The following is a description of a gene set: from publication Olex AL, Hiltbold EM, Leng X, Fetrow JS (PMID 20682054) Human Gene Set: GSE21033_CTRL_VS_POLYIC_STIM_DC_3H_UP Genes up-regulated in bone marrow-derived dendritic cellstreated by poly(IC): 0h versus 3h. studied in species Homo sapiens BACKGROUND: Dendritic cells (DC) play a central role in primary immune responses and become potent stimulators of the adaptive immune response after undergoing the critical process of maturation. Understanding the dynamics of DC maturation would provide key insights into this important process. Time course microarray experiments can provide unique insights into DC maturation dynamics. Replicate experiments are necessary to address the issues of experimental and biological variability. Statistical methods and averaging are often used to identify significant signals. Here a novel strategy for filtering of replicate time course microarray data, which identifies consistent signals between the replicates, is presented and applied to a DC time course microarray experiment. RESULTS: The temporal dynamics of DC maturation were studied by stimulating DC with poly(I:C) and following gene expression at 5 time points from 1 to 24 hours. The novel filtering strategy uses standard statistical and fold change techniques, along with the consistency of replicate temporal profiles, to identify those differentially expressed genes that were consistent in two biological replicate experiments. To address the issue of cluster reproducibility a consensus clustering method, which identifies clusters of genes whose expression varies consistently between replicates, was also developed and applied. Analysis of the resulting clusters revealed many known and novel characteristics of DC maturation, such as the up-regulation of specific immune response pathways. Intriguingly, more genes were down-regulated than up-regulated. Results identify a more comprehensive program of down-regulation, including many genes involved in protein synthesis, metabolism, and housekeeping needed for maintenance of cellular integrity and metabolism. CONCLUSIONS: The new filtering strategy emphasizes the importance of consistent and reproducible results when analyzing microarray data and utilizes consistency between replicate experiments as a criterion in both feature selection and clustering, without averaging or otherwise combining replicate data. Observation of a significant down-regulation program during DC maturation indicates that DC are preparing for cell death and provides a path to better understand the process. This new filtering strategy can be adapted for use in analyzing other large-scale time course data sets with replicates., and this is the list of marker genes: RAB5IF, BEX4, SMIM8, BRD7, PIM2, TRIM58, ORC1, ARMC6, TSC22D4, COA3, SNUPN, FASTK, TTC33, ZKSCAN4, EI24, JARID2, SLC16A10, PLCB1, MRFAP1L1, ACAD8, COQ8A, PPM1H, POLR3B, SCYL3, HELZ, MRPL17, TTK, CD164, ANXA11, MTMR3, FNBP1, RABEPK, LPCAT4 (lysophosphatidylcholine acyltransferase 4), TNFSF10, UBA7, VIPAS39, TRAPPC2, LRRC47, NDUFC2, AVEN, SLC30A4 (solute carrier family 30 member 4), FN3KRP, PDCL, COASY, FXR1, PIGH, TUT4, RHOG, PSMF1, BCOR, MYH1, HINT1, ELOA-AS1, CRAT, MYO1D, CTNNBIP1, PFAS, MIS18A, RBPJ, TDP2 (NCBI Gene Id 51567), CSE1L, CD244, PTPRA, ZNF768, DCUN1D2, CENPU, RUSF1, KIF11, POU2F1, MEGF9, CDC7, ELMO1, CREG1, CNOT9, ZZZ3, RPRD2, GSTK1, DLGAP5, NPIPA1, PWP1, TSPAN14, CLCN5, TST, MAP3K3, PKD1P6, TMEM177 (transmembrane protein 177), SH2D3A, PIK3R3, MDFIC, REPS1, MDC1, HNRNPUL1, ZNF177, NAP1L4, JUP, FTO, BMAL1, NAT10, ATP5PD, MTERF3, BAG2, RAB4A (RAB4A, member RAS oncogene family), WDR25, RAD9A (NCBI Gene Id 5883), TBC1D13, NIPAL3, ANAPC5, SLC35F6, CEP68, PACSIN2, TAF11, POP4, B3GAT3, CEP72, IMPACT, RSAD1, HTRA2, RPS24, PIP4K2B, F2RL3, TAF5, FAM193B, STAG3, FBXO46, PUDP (NCBI Gene Id 8226), PRKACA, ASH2L, TXNDC15, GRK5, PHKB, DDX24, LPCAT1 (NCBI Gene Id 79888), GNB5, HMGN3, NARS1, GDI2, PCYOX1L, PTPN18, FAM168A, ANKRD27, PKD1P1, MSRB2, COLGALT1, FUT8, AP2S1, DYNC1H1, DDX46, TDRD3, KAZN, POLR2B, RNF13, ZNF391, EBAG9, PMS2P2, CBLB, STX10, TP53, THUMPD1, MKKS, AP5M1, SUPT7L, MTMR4, AKAP1, EXOC1, ORC6, BBS4, PKP4, KDELR2, RAD17, RBM25, PSMA4, FZD3, GLCE, EFNA3, UBR7, ZNF135, PTTG3P, PSMG2, PRDX3, LST1, PCMTD2, RABIF, MLLT3, MED16, PRIM1, ADAM10, CEP192, ELAVL1, SLC1A4, MIEF1, MPI, TUBA3D, ZNF184, NLRX1, CLN5, ZDHHC7, CHST10, RANGRF, VPS16, ENTPD5